Given this list of marker genes Areg, Esr1, Tfap2c, Med1, Wnt5a, here is a description of the gene set: The multiplication or reproduction of mammary gland branch epithelial cells, resulting in the elongation of the branch. The mammary gland branch differs from the bud in that it is not the initial curved portion of the outgrowth. Mouse Gene Set: GOBP_EPITHELIAL_CELL_PROLIFERATION_INVOLVED_IN_MAMMARY_GLAND_DUCT_ELONGATION studied in species Mus musculus